The following is a description of a gene set: An early-differentiated CD8+ memory T cell subset with stem cell-like properties (TSCM) can be identified within the naïve-like T cell population by the expression of CD95/Fas. Based on experiments including exon- and gene-level expression analysis, we provide evidence that this subset of antigen-specific cells represents an early precursor of conventional central (TCM) and effector (TEM) memory CD8+ T cells with enhanced self-renewal capacity and proliferative potential. We identified genes differentially expressed between major T cell subsets defined along with memory T cell commitment. Based on the analysis of these genes, CD95+ naïve T cells (TSCM) cluster closer to the CD8+ T memory compartment than to classical (CD95-) naïve T (TN) cells, and display an intermittent phenotype between classical TN and TCM cells in terms of all major T cell differentiation markers analyzed. Genes down-regulated in CD8 T cells: central memory versus effector memory. from publication Gattinoni L, Lugli E, Ji Y, Pos Z, Paulos CM, Quigley MF, Almeida JR, Gostick E, Yu Z, Carpenito C, Wang E, Douek DC, Price DA, June CH, Marincola FM, Roederer M, Restifo NP (PMID 21926977) species: Homo sapiens Human Gene Set: GSE23321_CENTRAL_VS_EFFECTOR_MEMORY_CD8_TCELL_DN, and this is the list of marker genes: PAG1, BANF1, BLOC1S3, ITFG2, TIMMDC1, CXCR6, EMP1, RACK1, ITLN1, ZNF521, DHX32, MARCHF7 (membrane associated ring-CH-type finger 7), PSTPIP2, CCDC90B, UCHL3, ST3GAL6, COA7, RNF187, RPL36, ABHD8, DDX10, F8A1, CTSV, IFT25, FBLN1, PARP16, PRXL2A, TRMT10B (NCBI Gene Id 158234), TKT, NUMA1, CRYBA2, SPSB3, CCNDBP1, DLG1, CAP2, CTSD, MTIF2, ERBB2, RPL37, BCL2L11, IL5RA, MDM1, BPHL, TMEM87A, XPC, STX2, SGK3, RSPH6A, PLA2G4F, GALNT4, SPPL3, MCOLN3, ACYP1, SPICE1, CNBP, PLXNA3, HYPK, DHCR24, MTERF2, NUP58, VPS39, PRPF19, KDM3A, CDC16, PRICKLE1, PPP1R37, MRPS2, INMT, MRRF, MITF, F2R, EMC6, TMEM80, TRIT1, GADD45A, TMCO6, TUBA4A, TCTA, RMDN1, TMEM60, BICDL1, KRAS, MAP3K6, IFT81, VIPR1, TMEM230, RABEP2, ARFGAP2, DENND6A, ADH1C, EHBP1, AFP, HAL, ZAN, XPA, POLG2 (DNA polymerase gamma 2, accessory subunit), TLE4, YWHAZ, IPO11, ZBTB22, DDRGK1, TMEM63B, WLS, RAB24, CPNE6, CCDC71, SPTSSA, DIMT1, ZC3H8, E2F6, EIF3E, TAF13, UFD1, MEF2A, ARID3B, MAP4K3, NME4, SORD, TCEAL8, NTN4, DDX20, RPL18, FAM118A (family with sequence similarity 118 member A), RAD54L2, SMIM12, AKAP12, RPL11, GRIN2B, ART4, ANTXR2, FBXL14, SNX5, PHB1, RALA, ELOVL7, NDUFA10, ACADM, STARD4, CCDC59, BRD7, ZDHHC12, MRPL10 (NCBI Gene Id 65004), FGD4, CD47, NEDD4L, RPAP1, ARL4C, ADH5, CACNA2D2, IFT70B, BBS2, ERCC1, LMO4, CUTC, CSTF1, COA6, CNR2, EHD3, AAAS, TRMT10A (NCBI Gene Id 93587), SNX30, TSEN15, SATB1, ADAT2, HDAC6, SLC27A4, IRF4, LRRC23, POC5, SLC7A6, KIF2A, THOC1, BCAS2, PPM1B, RORA, HLA-DOB, STYX, SP1, HNRNPH1 (NCBI Gene Id 3187), PSTK, PTCD2, FAM234B, SDHAF4, PGLYRP2, MYLIP, COA3, MGST1, METTL9, RPS4X, NNT, IRF6, CDC23, WDR46, MARCHF2, SURF4, KANSL1L, PRKD3, SLC6A15, WASF1, CEP20